Given this list of marker genes Dlst, Mat1a, Aadat, Tha1, Pipox, Tdh, Ddo, Aass, Asrgl1, Gcat, Got2, Got1, here is a description of the gene set: studied in species Mus musculus Mouse Gene Set: GOBP_ASPARTATE_FAMILY_AMINO_ACID_CATABOLIC_PROCESS The chemical reactions and pathways resulting in the breakdown of amino acids of the aspartate family, comprising asparagine, aspartate, lysine, methionine and threonine.